Given this list of marker genes SH3TC2, RAB4A, MPZ, MTMR2, NDRG1, FIG4, DNM2, RAB3B, GDAP1, EGR2, RAB7A, RAB4B, HSPB8, HSPB1, KIF1B, NEFL, FGD4, RAB11B, PMP22, SBF2, LRSAM1, RAB11A, MFN2, RABAC1, LITAF, RAB25, RAB3A, here is a description of the gene set: Intracellular trafficking proteins involved in CMT neuropathy studied in species Homo sapiens Human Gene Set: WP_INTRACELLULAR_TRAFFICKING_PROTEINS_INVOLVED_IN_CMT_NEUROPATHY